The following is a description of a gene set: studied in species Homo sapiens Genes predicted to be targets of miRBase v22 microRNA hsa-miR-22-5p in miRDB v6.0 with MirTarget v4 prediction scores > 80 (high confidence targets). from publication Chen Y, Wang X (PMID 31504780) Human Gene Set: MIR22_5P, and this is the list of marker genes: ERC1, CAST, SRPRA, ATP6V1G3, AADAT, WDR47, RGS1, PTPN3 (protein tyrosine phosphatase non-receptor type 3), VPS50, SCAI, SOCS5, EIF2S1, BORCS5, RAP1GDS1, CXXC5, ARHGAP21, ABCD3, ZBTB20 (zinc finger and BTB domain containing 20), DLG2, SAMD8, BAZ1B, CENPL, TXNL4B, CDCA2, ONECUT2, TP53BP2, FBXO33, AFF2 (ALF transcription elongation factor 2), LIMD1, RBPJ (recombination signal binding protein for immunoglobulin kappa J region), PSMA1, MBNL1 (NCBI Gene Id 9850), CCSER1, LATS2, C14orf39, KRTAP24-1, CBX3, SEC24A, MMAA, PTPN1, LARP4, C1QTNF3, TENT2, FNDC3A, TLE4, GOT2, RALA (NCBI Gene Id 5898), RBM46, ELOVL2, RGPD5, DLG3, TXN2, DENND10, MPRIP, GCC2, ENTPD5, SNX25, RAB39A, ACSS3, OPA1, PPP1R14C, PDE1C, ZNF704, UXS1, PSMD8, NAA15, NDUFA12 (NADH:ubiquinone oxidoreductase subunit A12), LYN, ZNF280D, PAPPA2 (NCBI Gene Id 60676), MRPL43, ERBIN, KIF14, DIAPH2, TPD52L2, HNRNPK, EVI5 (ecotropic viral integration site 5), JPT1, PHTF2, GALNTL6, ALS2, NR1D2, TBC1D32, AFTPH, SYT4, VLDLR, LACC1, SEMA3A (semaphorin 3A), TSTD1, SUCO, KCNQ3, NETO1, RBM27, ZNF180, EPHA4, SERPINB8 (NCBI Gene Id 5271), CELF4, USH2A, PTPN4, ZDHHC15, GPR34, ACLY, LEPR, DDI2, ZSWIM6, REPS2, CNR1, CYP4Z1, AKAP12, MAP4K3, SMG1, MINPP1, SRP19, CC2D2A, NAP1L1, C17orf75, GATA6, NEDD4L, XIRP2, TMCC1, ESM1, FRMPD4, TMBIM4, FUBP3, RPGRIP1L, MLLT10, MB21D2, LRBA, PDE10A, SRR, ELK4, TENM1, ZNF300, CHTF8, TSPAN2, GLS, LYPLA1, VGLL4, IARS1, KITLG, GPBP1, RAP1A (RAP1A, member of RAS oncogene family), NEUROG2, KANK2